The following is a description of a gene set: The reciprocal chromosomal translocation t(4;11) is correlated with infant, childhood, adult and therapy-related high-risk acute leukemia. Here, we investigated the biological effects of MLL.AF4, AF4.MLL or the combination of both reciprocal fusion proteins in a conditional in vitro cell culture model system. Several parameters like cell growth, cell cycling capacity, apoptotic behavior and growth transformation were investigated under physiological and stress conditions. Co-transfected cells displayed the highest resistance against apoptotic triggers, cell cycling capacity and loss-of-contact inhibition. These analyses were complemented by gene expression profiling experiments and specific gene signatures were established for each of the three cell lines. Interestingly, co-transfected cells strongly upregulate the homeobox gene Nanog. In combination with Oct4, the Nanog homeoprotein is steering maintenance of pluripotency and self-renewal in embryonic stem cells. Transcription of Nanog and other stem cell factors, like Oct4 and Bmi1, was verified in biopsy material of t(4;11) patient cells which express both reciprocal t(4;11) fusion genes. In conclusion, the presence of both reciprocal MLL fusion proteins confers biological properties known from t(4;11) leukemia, suggesting that each of the two fusion proteins contribute specific properties and, in combination, also synergistic effects to the leukemic phenotype. Mouse Gene Set: GAUSSMANN_MLL_AF4_FUSION_TARGETS_D_DN studied in species Mus musculus Down-regulated genes from the set D (Fig. 5a): specific signature shared by cells expressing MLL-AF4 alone and those expressing both MLL-AF4 and AF4-MLL fusion proteins. from publication Gaussmann A, Wenger T, Eberle I, Bursen A, Bracharz S, Herr I, Dingermann T, Marschalek R (PMID 17130830), and this is the list of marker genes: Aldh1a1, Apobr, Pxylp1, Afp, Gpc1, Slc35c2, Ccny, Zfp979, Gpc6, Dusp4